The following is a description of a gene set: studied in species Homo sapiens Mutation-caused aberrant SOD1 to PERK-ATF4 signaling pathway. Pathway ID: N01149. Pathway type: Variant. Pathway class: nt06534 Unfolded protein response. Pathway Definition from KEGG: SOD1* -| BIP -| EIF2AK3 -> EIF2S1 -> ATF4 => DDIT3 Human Gene Set: KEGG_MEDICUS_VARIANT_MUTATION_CAUSED_ABERRANT_SOD1_TO_PERK_ATF4_SIGNALING_PATHWAY, and this is the list of marker genes: EIF2AK3, EIF2S1, SOD1, HSPA5, DDIT3, ATF4